The following is a description of a gene set: Human Gene Set: MIR942_3P species: Homo sapiens from publication Chen Y, Wang X (PMID 31504780) Genes predicted to be targets of miRBase v22 microRNA hsa-miR-942-3p in miRDB v6.0 with MirTarget v4 prediction scores > 80 (high confidence targets)., and this is the list of marker genes: PPTC7, PTK2, MTMR4, MYT1L, B4GALT5, MBOAT2, USP53, DLX5, VKORC1L1, GLCCI1, LYRM7, COL12A1, REST, GRK5, GABRA2, MBL2 (NCBI Gene Id 4153), AHCYL1, HIPK3, AKAP12, NKX2-2, NUP153, KANSL1, SDAD1, FAM114A2, KRT84, PLCB4, LDB2, RGMB, EPHA5, CTNNA3, UBE2D3, GALNTL6, YTHDF3, TRPC5OS, SOX6, PRRC1, RNF44, SLITRK3, BBX, KDM1A, ZNF107, ECT2, METAP2 (methionyl aminopeptidase 2), PROX1, SENP1, SLC35E4, MIA3, RHOBTB1, NUFIP2, RASAL2, ZMYM2, KDM1B (NCBI Gene Id 254751), KCNH8, SLC25A16, NKAPD1, SPEF2, EPC2, NRG1, LENG8, ATP1B1, YWHAZ, EML6, PPP3R1, PLCB1, MYSM1, PGGT1B, SMIM10L1, WDR20, LZTS1, SERINC1, PHOSPHO1, PDCD4, ATP5MC3, CHIC1, PRR14L, BICD2, ZNF550, ZNF329, CDKN2B, NRBP2, ESYT2, HKDC1, MPP7, MGAT4A (NCBI Gene Id 11320), SOS2, PRDM1, DOCK7, AJAP1, WDR72, COX5A, GAS1, NOTCH2, CDC73, SLBP, RGS4, TAF13, CSMD1, INPP4A, ATAD1, GLUL, CLK1, RIMOC1, ADAMTS6, MIER3, FBXO8, HTR2C, GPATCH2L, IL15, GAPDH, RNF214 (NCBI Gene Id 257160)